The following is a description of a gene set: Acting as a marker to identify a membrane and interacting selectively with one or more SNAREs on another membrane to mediate membrane fusion. studied in species Homo sapiens Human Gene Set: GOMF_SNAP_RECEPTOR_ACTIVITY, and this is the list of marker genes: TSNARE1 (NCBI Gene Id 203062), BET1L, STX3, USE1, VAMP7, STX6, VAMP8, STX10, STX7, STX19, SNAP47, VTI1B, STX8, STX12, VTI1A, STX1A, STX5, SNAP29, STX4, STX17, SEC22A, STX1B, STX18, STX16, SEC22B, STX11, BNIP1, BET1, VAMP1, STX2, SNAP23, VAMP3, GOSR2, SNAP25, GOSR1, YKT6, VAMP2 (vesicle associated membrane protein 2)